Given this list of marker genes CYP2R1, CYP27B1, SLC34A3, PHEX, ALPL, CTNS, SLC34A1, here is a description of the gene set: Human Gene Set: HP_RACHITIC_ROSARY studied in species Homo sapiens A row of beadlike prominences at the junction of a rib and its cartilage (i.e., enlarged costochondral joints), resembling a rosary. Note that rachitic rosary would have one bead per rib (a swelling at the costochondral junction), while beaded ribs in the context of multiple rib fractures have multiple beads (fractures) along the same rib. Rachitic rosary